The following is a description of a gene set: Genes predicted to be targets of miRBase v22 microRNA mmu_miR_541_5p in miRDB v6.0 with MirTarget v4 prediction scores > 80 (high confidence targets). Mouse Gene Set: MIR_541_5P studied in species Mus musculus from publication Chen Y, Wang X (PMID 31504780), and this is the list of marker genes: Gab1, Mmp1a, Cxcl16, Lrrc19, St13, Gm11541, Kpna1, Stk3, Nfasc, Gpr34, Mmp1b, Hycc2, Pxdn, Zfp292 (zinc finger protein 292), Gstm7, Fbxw7, Hoxd10 (homeobox D10), Sclt1, Arid2, Sorcs1, Kif16b, Kcnj2 (potassium inwardly-rectifying channel, subfamily J, member 2), Btbd9, Lbr, Ift74, En2, Brd10, Itga4 (integrin alpha 4), Srsf10, Rpgrip1l, Smad4, Cyp2c39